Given this list of marker genes IRF1, CCDC134, CD300LF, IRF7, CD300A, here is a description of the gene set: species: Homo sapiens Any process that modulates the frequency, rate, or extent of MyD88-dependent toll-like receptor signaling pathway. Human Gene Set: GOBP_REGULATION_OF_MYD88_DEPENDENT_TOLL_LIKE_RECEPTOR_SIGNALING_PATHWAY